The following is a description of a gene set: Congenital blindness species: Homo sapiens Human Gene Set: HP_CONGENITAL_BLINDNESS Blindness with onset at birth., and this is the list of marker genes: NSMCE2, SARDH, LRAT, LRP5, RD3, ATIC, XRCC4, CEP290